Given this list of marker genes SIRT1, HCAR2, ANXA1, PIK3CB, PIK3CD, FCAR, NF1, ADIPOQ, CDKN2A (NCBI Gene Id 1029), MEF2C, here is a description of the gene set: Any process that activates or increases the frequency, rate, or extent of myeloid cell apoptotic process. species: Homo sapiens Human Gene Set: GOBP_POSITIVE_REGULATION_OF_MYELOID_CELL_APOPTOTIC_PROCESS